Given this list of marker genes SLC38A5, SLC38A3, SLC15A4, SLC7A1 (NCBI Gene Id 6541), SLC66A1, here is a description of the gene set: Human Gene Set: GOMF_L_HISTIDINE_TRANSMEMBRANE_TRANSPORTER_ACTIVITY species: Homo sapiens Enables the transfer of L-histidine from one side of a membrane to the other. L-histidine is 2-amino-3-(1H-imidazol-4-yl)propanoic acid.